Given this list of marker genes Gm32496, Zfand1, 4930539M17Rik, Slc7a12 (solute carrier family 7 (cationic amino acid transporter, y+ system), member 12), Gm6140, Gm8935, Gm6162, Bhlhe22, Gm16685, Fabp5, Pkia, Sirpb1b, Fabp4, Gm8747, Gm8957, Gm21631, Fabp9, Pmp2, Gm8823, C030034L19Rik, Chmp4c (NCBI Gene Id 74324), Gm19114, Gm17806, Il7, Pag1, Gm18822, Hnf4g, Gm8939 (NCBI Gene Id 675259), Gm10745, Gm17308, Gm8955, Gm5272, Sirpb1c, Sirpb1a, Gm6236, Gm22944, Gm23592, Gm8860, Gm34023, Gm10748, Gm5844, Car2, Ythdf3, Myef2l, Gm8775, Gm17877, Gm24963 (NCBI Gene Id 115489827), Gm19175, Fabp12, Hey1, Rps24-ps2, 2700069I18Rik, Zbtb10, Gm15466, Gm6321, A930014E01Rik, Gm29747, Gm7132, Pex2, Gm19694, Gm37996, A930001A20Rik, Gm30340, 4632432E15Rik, Rbis, Gm22074, Gm7103, Car1, Gm2077, Gm37164, Gm18658, Ralyl (RALY RNA binding protein-like), E2f5, Gm5843, Gm2464, 4930555M17Rik, Snx16, Zfp704, 1110015O18Rik, n-R5s194, Zc2hc1a, 1700010I02Rik (NCBI Gene Id 75476), Gm16399, Gm7343 (predicted gene 7343), Gm17934, Gm18692, Lrrcc1, Gm26485, Slc10a5, Pou5f1-rs3, Cypt12, Car3, 1700008P02Rik, Gm6369, Gm5283, Gm22795, Stmn2, Sirpd, Gm8797, Gm23441, Or2q2-ps1, Gm24614, Impa1, 4930433B08Rik, Mir124a-2, Car13, Gm5841, Gm6300, Gm33819, C230057A21Rik, Mir124-2hg, Gm8919, Gm2429, Mrps28, Gm6350, Cyp7b1, 1700029B24Rik, Gm8826, Gm5150, Gm37358, Gm2474, Zfhx4, Gm23112, Tpd52, here is a description of the gene set: Mouse Gene Set: chr3A1 species: Mus musculus